The following is a description of a gene set: from publication Duan Z, Person RE, Lee HH, Huang S, Donadieu J, Badolato R, Grimes HL, Papayannopoulou T, Horwitz MS (PMID 17636019) Gfi1 transcriptionally governs hematopoiesis, and its mutations produce neutropenia. In an effort to identify Gfi1-interacting proteins and also to generate new candidate genes causing neutropenia, we performed a yeast two-hybrid screen with Gfi1. Among other Gfi1-interacting proteins, we identified a previously uncharacterized member of the PR domain-containing family of tumor suppressors, PRDM5. PRDM5 has 16 zinc fingers, and we show that it acts as a sequence-specific, DNA binding transcription factor that targets hematopoiesis-associated protein-coding and microRNA genes, including many that are also targets of Gfi1. PRDM5 epigenetically regulates transcription similarly to Gfi1: it recruits the histone methyltransferase G9a and class I histone deacetylases to its target gene promoters and demonstrates repressor activity on synthetic reporters; on endogenous target genes, however, it functions as an activator, in addition to a repressor. Interestingly, genes that PRDM5 activates, as opposed to those it represses, are also targets of Gfi1, suggesting a competitive mechanism through which two repressors could cooperate in order to become transcriptional activators. In neutropenic patients, we identified PRDM5 protein sequence variants perturbing transcriptional function, suggesting a potentially important role in hematopoiesis. Direct targets of PRDM5. studied in species Homo sapiens Human Gene Set: DUAN_PRDM5_TARGETS, and this is the list of marker genes: CYB5D1, CACNA1C, PIAS3, SOX2, PAX5, NOTCH2 (NCBI Gene Id 55574), MYC, PALM2AKAP2, ID2 (inhibitor of DNA binding 2), ISLR2, MYOM2, CDH4, TCEANC, CKLF, ACSBG1, INSYN1, POU2F3, ISLR, CLDN16, CD99, MYB, GABPA, MYD88, RUNX1, CMKLR2, GOLGA6A, ZFPM1, NAV2, CYP3A7, LRRC37A3, EBF1, UBL7, CCDC33, STK32C, TP53, TINAGL1, IL6R, GCK, PML, SIK1, RARA, GADD45B, PAX6, OVOL1, EDNRA, NOTCH1, EMID1, E2F3, ETS2, CEMIP, RXRB, SNRNP48, ARID3B, FBXO33, DKK3, ADARB2, EED, PSG1, CLK3, NLRC5 (NLR family CARD domain containing 5), S100A2, COL19A1, SOCS3, NREP, PPIL2, APOBEC3B, POU5F1, PPP1R12B, WNT10B, ALX4, INTS3, PHC1, H4C16, CDC42EP4, NCOA7, ENO2, EVL